The following is a description of a gene set: The process whose specific outcome is the progression of a mesangial cell in the kidney over time, from its formation to the mature structure. Mouse Gene Set: GOBP_MESANGIAL_CELL_DEVELOPMENT studied in species Mus musculus, and this is the list of marker genes: Pdgfb (platelet derived growth factor, B polypeptide), Osr1, Acta2, Foxc2, Gpr4, Notch1